The following is a description of a gene set: Any process that increases the frequency, rate or extent of a pyroptotic inflammatory response. studied in species Mus musculus Mouse Gene Set: GOBP_POSITIVE_REGULATION_OF_PYROPTOTIC_INFLAMMATORY_RESPONSE, and this is the list of marker genes: Gbp2, Zdhhc9, Gm12250, Zdhhc5, Gbp2b, Casp3, Gbp5, Gbp3